Given this list of marker genes NPNT, BCL2, UBLCP1, NOP56, PPIL4, SERTAD3, NCOA1, COL15A1, CBY1, ITGAL, MRPL42, EXOSC2, PRKAR1B, CD8B, KCNJ4, KCNH3, TMCC3, CHST2, SARDH, PSMB7, CTLA4, VMA21 (vacuolar ATPase assembly factor VMA21), SDC3, COL16A1, TPGS2, PTGFRN, SUCO, MDH2, SNX10, ICMT, MTMR6, AXL, AKIRIN1, JKAMP, MR1, SRPX, IMPACT, KLHL20, VBP1, UGGT2, ANKRD1, PILRB, PCYOX1, ADD3, CLCN7, EPHA3, ATG7, NFATC2IP, PHOX2A (paired like homeobox 2A), ATP1B3, SAG, CEMIP2, NPHS2 (NCBI Gene Id 7827), MAPK14, RRM1, OTUD5, KIF20A, KIF3C, PLXNC1, PTPRA, DERL3, BGN, PTGFR, HTRA1, TWSG1, ASAH2 (NCBI Gene Id 63292), LRRK2, HACD1, STRN3, SLC38A10, TLR2, HDAC6 (NCBI Gene Id 100820762), IL18BP, NOPCHAP1, COL4A3, PDE6C, KCNJ5, POLR1E, PHF20, PROS1, UBA3, SGCB, PKNOX2 (PBX/knotted 1 homeobox 2), CYBB, B4GALT4, KAT2A, BFSP1, GHDC, ACTN4, NUP160, ITM2B, LCN8, GPR89B, H2AX, EXOSC10, TCF25, PRPSAP2, EIF2AK4, CTTNBP2NL, FANCL, CFAP298, PRPF8, FBXO2, CMTR1, TMCO1, STAU1, RCAN1, TMED7, HMGCR, CARHSP1, FIG4, SERPINF1, SERPINA10, RRP15, SKIC8, COPZ2, LEPROT, HSPA5, MYH9, SH2D1B, SETD7, CHGA, PSEN1, SLC2A9, COX5A, TBRG1, SQSTM1, PRELP, KIAA1191, SORCS1 (sortilin related VPS10 domain containing receptor 1), UBE2D3, EIF4E, RNF149, CZIB, ACER2, SLC12A5, PRKAR2A, DNAJC1, RNGTT, RBP3, GPR3, EPB41L2, LAIR1, PMP22, CRADD, GALM, ACD, SMAD1 (NCBI Gene Id 4086), TSPAN12, SEPTIN2, MS4A8, MYEF2, AREG, HSDL2, UBAP2L, POSTN, CD302, ABCA2, TUBB4A, EMC4, PTCD1, COPS3, CDK5R1 (NCBI Gene Id 8851), ABCD2, PRKCA, RANBP17, ROBO1, GOLGA3, ANXA6, SLC31A2, GCLC, TYRO3 (TYRO3 protein tyrosine kinase), RIOK2, EDNRB, DNAJA2, PIP4K2B, SGO1, PIK3AP1, M1AP, RPS6KB2, NT5C2, ZP1, MYL9 (NCBI Gene Id 10398), FN1, KCNJ11, RNF4, LGALS9B, SARAF (NCBI Gene Id 95251), CTSS, OSGIN2, PSMD8, ACKR3, APTX, CERS5, AKT3, IKZF1, EEF1E1, SYT12, SEPHS2, SMYD1, here is a description of the gene set: Human Gene Set: GSE20715_WT_VS_TLR4_KO_6H_OZONE_LUNG_UP studied in species Homo sapiens We previously identified toll-like receptor 4 (Tlr4) as a candidate gene responsible for ozone (O3)-induced pulmonary hyperpermeability and inflammation. The objective of this study was to determine the mechanism through which TLR4 modulates O3-induced pulmonary responses and to utilize transcriptomics to determine TLR4 effector molecules. C3H/HeJ (HeJ; Tlr4 mutant) and C3H/HeOuJ (OuJ; Tlr4 normal), mice were exposed continuously to 0.3 ppm O3 or filtered air for 6, 24, 48 or 72 hr. Affymetrix Mouse430A_MOE gene arrays were used to analyze lung homogenates from HeJ and OuJ mice followed using a bioinformatic analysis. Inflammation was assessed by bronchoalveolar lavage and molecular analysis by ELISA, immunoblotting, and transcription factor activity. TLR4 signals through both the MYD88-dependent and independent pathways in OuJ mice, which involves MAP kinase activation, NF-kappaB, AP-1, and KC. Microarray analyses identifiedTLR4 responsive genes for strain and time in OuJ versus HeJ mice (p<0.05). One significantly upregulated cluster of genes in OuJ were the heat shock proteins (Hspa1b; Hsp70), Hsp90ab1). Furthermore, O3-induced expression of HSP70 protein was increased in OuJ compared to HeJ mice following 24-48 h O3. Moreover, BAL polymorphonuclear leukocytes (PMN) and total protein were significantly reduced in response to O3 in Hspa1a/Hspa1btm1Dix (Hsp70-/-) compared to Hsp70+/+ mice (p<0.05). TLR4 signaling (MYD88-dependent), ERK1/2, AP-1 activity, and KC protein content were also significantly reduced after O3 exposure in Hsp70-/- compared to Hsp70+/+ mice (p<0.05). These studies suggest that HSP70 is involved in the regulation of O3-induced lung inflammation through the TLR4 pathway and provide evidence that HSP70 is an endogenous in vivo TLR4 ligand. from publication Bauer AK, Rondini EA, Hummel KA, Degraff LM, Walker C, Jedlicka AE, Kleeberger SR (PMID 21543283) Genes up-regulated in comparson of lung tissue from wild type mice subjected to ozone for 6 h vs that from TLR4 deficient animal subjected to ozone for 6 h.